Given this list of marker genes CLIP2, JAG1, LTBP1, PIGN, STX1A, NOTCH2, BAZ1B, ALDH18A1, IFT43, MGP, UBE2A, LIMK1, GTF2IRD2, PPP1CB, FKBP6, RFC2, CCNQ, ELN, NCF1, PIGL, SKIC2, GTF2I (NCBI Gene Id 90875), VPS37D, DNAJC30, EIF4H, BUD23, TAOK1, NAA10, BCOR, EFEMP2 (EGF containing fibulin extracellular matrix protein 2), SKIC3, LTBP4, GTF2IRD1, MLXIPL, FBLN5, TBL2, FGFR1, METTL27, PIGO, TMEM270, here is a description of the gene set: Peripheral pulmonary artery stenosis Human Gene Set: HP_PERIPHERAL_PULMONARY_ARTERY_STENOSIS Stenosis of a peripheral branch of the pulmonary artery. species: Homo sapiens